Given this list of marker genes IFNGR2, TYK2, IFNGR1, IFNL2, JAK1, IL10RB, IFNG, IFNLR1, IFNL1, IFNL4, IFNL3, here is a description of the gene set: Any process that results in a change in state or activity of a cell (in terms of movement, secretion, enzyme production, gene expression, etc.) as a result of a type III interferon stimulus. Interferon lambda is the only member of the type III interferon found so far. Human Gene Set: GOBP_CELLULAR_RESPONSE_TO_TYPE_III_INTERFERON species: Homo sapiens